The following is a description of a gene set: mBDNF and proBDNF regulation of GABA neurotransmission species: Homo sapiens Human Gene Set: WP_MBDNF_AND_PROBDNF_REGULATION_OF_GABA_NEUROTRANSMISSION, and this is the list of marker genes: GABRA5, GABRB2, PIK3CA, RHOA, SHC1, PIK3CG, GABRA3, NTRK2, PLCG1, GABRB1, AP2A1, PIK3R3, GABRA6, GABRD, GABRA1, BDNF, CREM (cAMP responsive element modulator), CREB1, SLC12A5, GABRE, JAK2, GABRP, GABRG2, AP2B1, GABRQ, PIK3R1 (phosphoinositide-3-kinase regulatory subunit 1), AP2A2, PTEN, GABRA4, GABRA2, GABRG3, PIK3R2 (NCBI Gene Id 5296), PIK3CB, GABRB3 (gamma-aminobutyric acid type A receptor subunit beta3), ROCK1, STAT3, GABRG1, NGFR